The following is a description of a gene set: Reactome Pathway: Biosynthesis of protectins This event has been computationally inferred from an event that has been demonstrated in another species.<p>The inference is based on the homology mapping from PANTHER. Briefly, reactions for which all involved PhysicalEntities (in input, output and catalyst) have a mapped orthologue/paralogue (for complexes at least 75% of components must have a mapping) are inferred to the other species. studied in species Mus musculus part of: Biosynthesis of DHA-derived SPMs electronically inferred by orthology from the curated human pathway, and this is the list of marker genes: Cyp1a2, Alox15, Lta4h, Cyp1a1